Given this list of marker genes GTF2IRD1, MSTN, MYOZ2, MIR499A, CFLAR, ACTN3, MYMK, TNNC1, TNNT1, MIR208B, IGFBP5, CACNA1S, TRIM63, PPP3CA, MYOD1, TNNI1, CAMK2G, CAMK2B, MYH7, ASB2, MYOZ1, MYOC, ATP2A2, here is a description of the gene set: Human Gene Set: GOBP_SKELETAL_MUSCLE_ADAPTATION studied in species Homo sapiens Any process in which skeletal muscles change their phenotypic profiles in response to altered functional demands and a variety of signals.